The following is a description of a gene set: Mouse Gene Set: GOBP_RESPONSE_TO_ENDOPLASMIC_RETICULUM_STRESS Any process that results in a change in state or activity of a cell (in terms of movement, secretion, enzyme production, gene expression, etc.) as a result of a stress acting at the endoplasmic reticulum. ER stress usually results from the accumulation of unfolded or misfolded proteins in the ER lumen. studied in species Mus musculus, and this is the list of marker genes: Canx, Dnajb12, Sgta, Os9, Ppp2cb, Psmc6, Trim13, Aifm1, Alox5, Jkamp, Alox15, Tmem67, Cep290 (centrosomal protein 290), Dab2ip, Nccrp1, Rnf145, Eif2ak2, Afg2b, Nr1h3, Edem1, Eif2b5, Creb3l2, Ecpas (Ecm29 proteasome adaptor and scaffold), Spop, Selenok, Atxn3, Thbs1, Cftr, Atf3, Nhlrc1, Nrbf2, Tmx1, Herpud1, Dnajc10, Map3k5, Ins2, Rnf183, Rhbdd1, Srpx, Parp16, Ikbkg, Selenos, Ubqln1, Creb3l3, Ppp1r15b, Ufl1 (UFM1 specific ligase 1), Bag6, Erlin1, Nrros, Trp53, Nck2, Bcl2l11, Marchf6, Kcnj8, Faf1, Fcgr2b, Stt3b, Pla2g6, Eif2ak4, Bak1, Nfe2l2, Nck1, Scamp5, Creb3l1, Erlin2, Bfar, Fis1, Ppp1r15a, Tmub1, Sec61b, Bcap31, Ufc1, Pmaip1, Derl3, Atad3a, Get4, Parp8, Lrrk2, Tmem129, Bok, Tmem238l, Nploc4, Man1b1, Pml, Bax, Eif2a, Qrich1, Atp2a1, Aup1, Hspa5, Ermp1, Bcl2, Bhlha15, Tmtc3, Ufm1, Lpcat3, Txndc12, Cops5, Ubac2, Cdk5rap3, App, Calr3, Pik3r2, Derl2, Tmem258, Tbl2, Ubxn1, Hyou1, Cert1, Fbxo17, Bbs10, Dnajb9, Opa1, Pigbos1, Abca7, Ube4b, Umod, Park7, Vapb, Anks4b, Serp2, Ubxn8, Sec61bl, Eif2s1, Dnajc3, Sesn2, P4hb, Sirt1, Tmem259, Crebrf, Jagn1, Sdf2l1, Ubxn4, Derl1, Tnfrsf10b, Yod1, Amfr, Tmub2, Trib3, Marcks, Rasgrf2, Tardbp, Edem2, Sgf29, Prkn, Ddit3, Chac1, D1Pas1, Atp2a3, Thbs4, Uba5, Bbs1, Clu, Clgn, Sel1l, Man1a2, Rnf185, Itpr1, Selenon, Niban1, Hsp90b1, Asb11, Igtp, Nr1h2, Ccdc47, Gorasp2, Agr2, Erp27 (endoplasmic reticulum protein 27), Faf2, Casp12, Syvn1, Dnajb2, Bcl2l1, Atf6b, Cebpb, Cav1, Usp25, Casp3, Edem3, Ddrgk1, Creb3 (cAMP responsive element binding protein 3), Usp19, Lhx1os, Ube2j1, Serinc3, Akt2, Ptpn1, Ddx3x, Erp29, Ubqln2, Tmem117, Vcp, Pdia2, Rasgrf1, Ankzf1, Flot1, Aqp11, Tmco1, Akt1, Rnf139, Rnft2, Ficd, Pik3r1, Erp44, Pdia4, Ube4a, Ern2, Ccnd1, Trim25, Aff4, Ubxn10 (UBX domain protein 10), Svip, Foxred2, Rnf5, Fbxo2, Bid, Calr4, Atf6, Gsk3b, Eif2ak3, Brsk2, Calr, Akt3, Atg10, Ube2j2 (ubiquitin-conjugating enzyme E2J 2), Nupr1, Jun, Grina, Map3k20, Wfs1, Nod2, Pmp22, Tmbim4, Manf, Mbtps2, Apaf1, Pdia6, Stub1, Sec16a, Ero1a, Ubxn2a, Atf4, Elavl4 (ELAV like RNA binding protein 4), Serp1, Parp6, Usp14, Ufd1, Rcn3, Tmbim6, Fbxo27, Dnm1l, Sel1l2, Usp13, Ube2k, H13, Pdx1, Tmem33, Fbxo6, Pdia3 (protein disulfide isomerase associated 3), Abl1, Casp9, Ifng, Ptpn2, Ern1, Stc2, Rnf121, Man1c1, Man1a, Rnft1, Fbxo44, Ube2g2, Erlec1, Herpud2, Bbc3, Tmed2, Ubxn6, Rnf186, Eif4g1, Nod1, Tmtc4, Xbp1, Tor1a, Rnf103, Nfe2l1, Rpap2